The following is a description of a gene set: from publication Chyla BJ, Moreno-Miralles I, Steapleton MA, Thompson MA, Bhaskara S, Engel M, Hiebert SW (PMID 18710942) While a number of DNA binding transcription factors have been identified that control hematopoietic cell fate decisions, only a limited number of transcriptional corepressors (e.g., the retinoblastoma protein and the nuclear hormone corepressor) have been linked to these functions. Here, we show that the transcriptional corepressor Mtg16 (myeloid translocation gene on chromosome 16), which is targeted by t(16;21) in acute myeloid leukemia, is required for hematopoietic progenitor cell fate decisions and for early progenitor cell proliferation. Inactivation of Mtg16 skewed early myeloid progenitor cells toward the granulocytic/macrophage lineage while reducing the numbers of megakaryocyte-erythroid progenitor cells. In addition, inactivation of Mtg16 impaired the rapid expansion of short-term stem cells, multipotent progenitor cells, and megakaryocyte-erythroid progenitor cells that is required under hematopoietic stress/emergency. This impairment appears to be a failure to proliferate rather than an induction of cell death, as expression of c-Myc, but not Bcl2, complemented the Mtg16(-/-) defect. Genes down-regulated in immature bone marrow progenitor cells upon knock out of CBFA2T3. species: Mus musculus Mouse Gene Set: CHYLA_CBFA2T3_TARGETS_DN, and this is the list of marker genes: Gdpd1, Slc22a23, Mgst3, Ell2 (NCBI Gene Id 192657), Slc11a2, Rtp1, Gls2, Erv3, S100a9, Abca3, Rnf128, Ublcp1 (NCBI Gene Id 79560, ubiquitin-like domain containing CTD phosphatase 1), Gm11837, Igsf3, Pdia2, Gsta4, Slc25a51, Cd82, Rab3il1, Mxd3, Arhgef25, Dync2i1, Gpsm2, Fzd7, Tspan15, Tac2, Slc7a7, Slc29a1, Ryk, Isg20, Tinagl1, Nqo1, Slc12a4, Pcx, Phlda2, Vamp1, Alas2, Bglap3, Cd177, Evi5, Tex264, S100a8, Mmp8, Ppp2r5b, Fntb (NCBI Gene Id 70263), Carhsp1, Gpc4, Parm1, Btrc, Slc38a9, Garem1, Marchf8, Enpp3, Spire1, Lcat, Septin4, Ntn4, Hpse2, Camp, Septin8, Sorbs1, Trim10, Epdr1, Rhag, 6330420H09Rik, Ptk2, 1700034P13Rik, Nipa1, Dkkl1, Cyp4f39, 1700001L05Rik, Rec8, Gm12185, Tns1, Abcg4, Pccb, Tmem72, Acp1, Dusp8, Wfdc21, Trim2, Zg16, Redrum, Ank1, B230206H07Rik, Ifitm6, Blvrb, Mgll, Gtf2h4, Mfsd9, Tuba8, Samd11, Osgepl1, 6030468B19Rik, Tspan8, Aldh1a7, Wdsub1, AV099323, Gstp3, Hpn, Lmna, Fn3k, Tspan33, Agpat3, H3f3a, Rhd, 2310022B05Rik, Klk1b26, Pxmp2, Klf5, Wrn (Werner syndrome RecQ like helicase), Zfp36l1, 6530409C15Rik, Zfp703, Tktl1, Ccdc74a, Trim17, Nscme3l, Paqr4, Ahcyl2, Tspo2, Tlcd4, Nefh, Klhdc8b, Kcnab1, Lmcd1, Slc39a8, Ces2b, Btnl10, Pgap3, Asprv1, 1110032F04Rik, Zbtb46, Sphk1, Megf9, Cldn13, Gm29677, Dclk2, Gm43868, Ctse, Rgs7bp, Fhdc1, Ypel4, Plxdc1 (NCBI Gene Id 72324), Lkaaear1, Slc6a20a, Agtr1a, Acot6, Or10x4, Sec14l2, Retnla, Cetn4, Igkv14-126, Mylk3, Chst10, Mfhas1, Agap1, C230066G23Rik, Mlf1, Kel, Nxpe4, Oas1c, Cnn1, Mboat2, Ptgs2os, Golm1, Gm11762, AA467197, Ly6k (NCBI Gene Id 76486), Aifm2, Zfp316, Gna14, Recql4, Nags, Ackr1, Yae1d1, Gm19696, Mmp14, Ngp, Tfr2, Clcn2, Slc38a5, Sh3tc2, Homer2, C230013L11Rik, Dhtkd1, Eya4, 1700066M21Rik, Bcl2l15, Fhit, Pik3r2, Or8b55, Paqr9, Dnase2a, Slc46a3, Emc9, Ampd3, Cela1, Slc30a10, Ltf, Cdr2, Scrn3 (secernin 3), Sh2d4a, Dmtn, 4930556H04Rik, Slc41a3, Aqp11, Oasl1, Hebp1, Ttc39a, Mylpf, Ranbp17 (NCBI Gene Id 80641), Carmil3 (capping protein regulator and myosin 1 linker 3), Radx, Pgap6, Ppm1l, Camsap2, Or14j6 (NCBI Gene Id 258374), Atp7b, Tgtp1, Slfn4, Mmp9, Fam234b, Lpin1, Creb3l2, Plpp1, Agpat4, Bcam, Irf7, A730036I17Rik, Tars3, Pde4a, Rfesd, Cenpv, Col5a1 (collagen, type V, alpha 1), Pm20d2, Zfp821, Sesn2, Shisa9, Adgrl2, Gal, Phyhip, 2600006K01Rik, C1qtnf12, Lrrc75aos2, Nfia, Retnlg (NCBI Gene Id 245195), H2bc27 (NCBI Gene Id 78303), 5730435O14Rik, Sqor, Sema6a, Lcn2, Gml2, Lrrc36, Bdh1, Igf2r, Rlig1, Chil4, Dnajb3 (DnaJ heat shock protein family (Hsp40) member B3), Smim1, Trak2, Epb42, Cntf, Pih1d2, Erfe, Ubac1, Gbp8, Fcmr, Matcap2, Inhca (NCBI Gene Id 71775), Krtcap3, Gm33111, Mettl5os, Asns, Mettl8, P4ha2, Asb17os, Chac2, Gm31887, Marveld2